Given this list of marker genes PDE4B, MAFF, SOD2, ID2, ABCA1, ZFHX3, G0S2, TTYH3, CDKN1A, MS4A4A, SH2B3, MIR22HG, MARCKS, MT-CO1, RILPL2, GPR34, CLN8, GPR84, IL18, TLR2, YBX3, AP1B1, SDCBP, FOSB, HTRA1 (HtrA serine peptidase 1), HLA-DRB1 (major histocompatibility complex, class II, DR beta 1), PLEK (pleckstrin), CTSZ, AKR1B1, TNFAIP2, MEF2C, C1QC, CD74, THBD, NFKBID (NCBI Gene Id 84807), FCGRT, PNRC1, MIDN, SELENOP, FCGR1A, FOLR2, LPAR6, CXCL1, MT-ND2, MT-ND3, RALGDS, DUSP6, MAP2K3, NFE2L2, MT-ATP6, RHOB, MFSD1, WSB1, NFKBIZ, SOCS3, ACSL1, GOLIM4, IL6, ETS2, ADAP2, CXCL3, SRGN, HSPA1A, GAS6, DUSP1, RNF130, C5AR1, WTAP, CYRIA, CFL1, HLA-DQB1, MERTK, HBEGF, CFLAR, KLF4, CTSS, INSIG1, FCGR2A, CSF1R, MXD1, DNAJB6, CD14, EIF4E, SLC40A1, CCL20, DDAH2, CTSB, CD93, LAIR1, MAP3K8, STAB1, RNF149, MSR1, ARL8B, PLAU, SLC43A2, NFKBIA, CCL3, HLA-DRA, PDGFB, IER3 (immediate early response 3), KLF6, DRAM1, PPP1R15B, QKI (QKI, KH domain containing RNA binding), CTSL, C1QA, SDS (serine dehydratase), HLA-DPA1, KDM6B, IRF8, RASGEF1B, CXCL8, DSE, OLR1, MT-ND1, CCL4, DAB2, NR4A2, GNA13, SLCO2B1, OGFRL1, PLD3 (phospholipase D family member 3), SLC16A10, TOP1, OAZ2, RAB31, RBM47, MAFB, JPT1, LST1, CPEB4, AP2A2, H3-3A, KCTD12, TMEM176B, CD83, RUNX1, HSPA1B, PFKFB3, TACC1, EGR1, PPP1R15A, ITM2B, CXCL2, MCL1, PLXND1, CCL4L2, ATP6V0D1, NEAT1, CPM, TRIB1, PRNP, ZFAND5, FGL2, CEBPD, MT-CO3, FPR1, CLEC7A, CPVL, PELI1, CTNNB1, TNFAIP3, IRF2BP2, RHOQ, CXCL16, FNIP2, OSM, PTGS2, PREX1, REL, IL10, OLFML3, ATP1A1, KYNU, CHMP1B, CD163, CEBPB, LYN, BCL2A1, MPEG1, ELL2, TREM2, ASAH1, LCP2, AFF4, NAMPT, RGS1, TNF, YWHAH, ZFP36, IL1B, LUCAT1, B3GNT5, NUMB, CCL2, NR4A3, ZFP36L1, SERPINB9, MGST2, SGK1, VSIG4, HLA-DMB, CSF2RA (colony stimulating factor 2 receptor subunit alpha), HLA-DMA, MIR155HG, PHACTR1, ATP1B3, IFNGR2, NRP2, NCOA4, MS4A7, HSPA6, RAC1 (NCBI Gene Id 5879), HERPUD1 (homocysteine inducible ER protein with ubiquitin like domain 1), A2M, STX11, GPR183, CYBB, NR4A1, MAFG, PSAP, NFKB1, AXL, OTUD1, HLA-DPB1 (major histocompatibility complex, class II, DP beta 1), HIF1A, C2, ATP2A2, PTPRE, LY86, C1QB, ZEB2, PLAUR, RTN4, SAT1, MT-CYB, SIRPA, LGMN, HLA-DQA1, NLRP3, PABPC4, USP53, TYMP, MNDA, AKAP13, ZNF267, RHBDF2, SEC14L1, LITAF, GADD45B, PIM3, CD81, MS4A6A, NFATC2, ABL2, ICAM1, CCRL2, here is a description of the gene set: Characterized by genes associated with inflammatory response, including cytokines and chemokines such as CLL3L1, CLL3, and CXCL2. Monocyte lineage marker CD68 was universally expressed. studied in species Homo sapiens from publication Su Z, Ho JWK, Yau RCH, Lam YL, Shek TWH, Yeung MCF, Chen H, Oreffo ROC, Cheah KSE, Cheung KSC (PMID 38267611) The transformation of benign lesions to malignant tumours is a crucial aspect of understanding chondrosarcomas, which are malignant cartilage tumours that could develop from benign chondroid lesions. However, the process of malignant transformation for chondroid lesions remains poorly understood, and no reliable markers are available to aid clinical decision-making. To address this issue, we conducted a study analysing 11 primary cartilage tumours and controls using single-cell RNA sequencing. By creating a single-cell atlas, we were able to identify the role of endoplasmic reticulum (ER) stress in the malignant transformation of conventional central chondrosarcomas (CCCS). Our research revealed that lower levels of ER stress promote chondrosarcoma growth in a patient-derived xenograft mouse model, while intensive ER stress reduces primary chondrosarcoma cell viability. Furthermore, we discovered that the NF-?B pathway alleviates ER stress-induced apoptosis during chondrosarcoma progression. Our single-cell signatures and large public data support the use of key ER stress regulators, such as DNA Damage Inducible Transcript 3 (DDIT3; also known as CHOP), as malignant markers for overall patient survival. Ultimately, our study highlights the significant role that ER stress plays in the malignant transformation of cartilaginous tumours and provides a valuable resource for future diagnostic markers and therapeutic strategies. Human Gene Set: SU_HO_CONV_CENT_CHONDROSARCOMA_LEUKOCYTE_C0_M1_MACROPHAGE